Given this list of marker genes LARP4, HNRNPU (heterogeneous nuclear ribonucleoprotein U), ZC3H14, RBMS1, RBMS3, EIF4A3, PATL1, MCRS1, PPIE, PNPT1, PABPC1L2B, PABPN1, PABPC5, PABPC1, PAN3, PABPN1L, PABPC1L, PABPC3 (NCBI Gene Id 91297), HNRNPDL, PABPC4, DDX3X, PABPC4L, DAZAP1, RBMS2, KHDRBS1, FMR1, ELAVL4, DDX1, PABPC1L2A, ATXN1, TIA1, KHDRBS2, here is a description of the gene set: studied in species Homo sapiens Binding to a stretch of purines (adenine or guanine) in an RNA molecule. Human Gene Set: GOMF_POLY_PURINE_TRACT_BINDING